The following is a description of a gene set: species: Homo sapiens The chemical reactions and pathways involving progesterone, a steroid hormone produced in the ovary which prepares and maintains the uterus for pregnancy. Also found in plants. Human Gene Set: GOBP_PROGESTERONE_METABOLIC_PROCESS, and this is the list of marker genes: EGR1 (early growth response 1), FSHB, DHRS9, AKR1C1, LHB, AKR1C4, CYP17A1, AFP, AKR1C3, STARD3, SCP2, ADM, AKR1C2, SRD5A1, STAT5B, CYP46A1, DGKQ